Given this list of marker genes Smad2, Ipo7, Dspp, Nfe2l1, Tgfb1, Ctnnb1, Bmp2, Tubb5, Bmp4, Cebpb, Fam20c (FAM20C, golgi associated secretory pathway kinase), Serpine1, Dlx3, Ift80, Msx1, Rptor, Map1b, Mir875, Lef1, here is a description of the gene set: studied in species Mus musculus Mouse Gene Set: GOBP_ODONTOBLAST_DIFFERENTIATION The process in which a relatively unspecialized cell of neural crest origin acquires the specialized features of an odontoblast, a cell on the outer surface of the dental pulp whose biological function is the creation of dentin.